Given this list of marker genes Atp2a1, Mcur1, Slc25a23, Micu2, Tgm2, Mcu, Rap1gds1, Micu1, Bnip3, here is a description of the gene set: studied in species Mus musculus Any process that increases the concentration of calcium ions in mitochondria. Mouse Gene Set: GOBP_POSITIVE_REGULATION_OF_MITOCHONDRIAL_CALCIUM_ION_CONCENTRATION